Given this list of marker genes Fgf10, Fgf3, Tbx1, Chd7, Tbx3, Hoxa1 (homeobox A1), Zeb1, Nr4a3, Eya1, Sparc, here is a description of the gene set: The process in which the anatomical structures of the semicircular canals are generated and organized. species: Mus musculus Mouse Gene Set: GOBP_SEMICIRCULAR_CANAL_MORPHOGENESIS